The following is a description of a gene set: studied in species Homo sapiens Catalysis of the reaction: an aldehyde + NAD(P)+ + H2O = an acid + NAD(P)H + H+. Human Gene Set: GOMF_ALDEHYDE_DEHYDROGENASE_NAD_P_PLUS_ACTIVITY, and this is the list of marker genes: ALDH2, ALDH3A1, ADH5, ALDH1A3, ALDH1L2, RDH11, ALDH3A2, ALDH1A2, ALDH9A1, ALDH3B1, ALDH1B1, ALDH3B2, ALDH4A1 (NCBI Gene Id 8659), ALDH1A1, ALDH1L1, ADH4, ALDH16A1, ALDH7A1